Given this list of marker genes TLX3, PRIM1, NUP107, ASPA, SFXN1, MZB1, DPH1, MGAT4C, CCDC112, KCNAB1, LRP8, VPS8, ANKRD9, SELENOV, EHMT1, MAN1B1, SPATA2L, IFI30, SIRT3, FBF1, SERBP1, KCNK2, PPP1R36, SLC25A31, RAMP1 (receptor activity modifying protein 1), P2RY1, NPM1, FREM2, ERAS (NCBI Gene Id 3266), MPV17L2, DMAP1, KRTAP19-3, WT1, PPP1R1C, DAZ2, TMPRSS11E, MTSS2, KANSL1, IGKC, MYOZ3 (myozenin 3), SCHIP1, BMPR1B, PRAMEF25, POLD1, CTNNBL1, ATP1B4, NDP, TLR3, SH2D4A, TDRD1, FOXD4L1, HHEX, MS4A13, CENPQ, SERPINB8, PADI6, ANKZF1, VIL1, CLDN5, TNS3 (tensin 3), OR2S2, IQCE, DCAF4, SLC47A1 (solute carrier family 47 member 1), MEF2C, COLEC11, IGLC7, ERC2, DPP10, ARHGAP33, TEX12, THEM4, TBCE, TUBG1, ADRA1B, BLOC1S2, LACTBL1, CISD1, ZDHHC13, KMO, TM7SF2, RNGTT (RNA guanylyltransferase and 5'-phosphatase), S1PR1, PAPLN, SLPI, SPON2, PRKAG3, TUBA4A, SIGLEC10, CADM2, GDPD1, TBX3, CYP17A1, SLC25A51 (NCBI Gene Id 92014), C7orf50, CABLES1, SETD1B (SET domain containing 1B, histone lysine methyltransferase), TBC1D31, MGST3, GPX6, PRAM1, OTUB2, LGALS8 (NCBI Gene Id 3964), ZNF454 (zinc finger protein 454), TREH, HLA-DQA1, TMEM184C, CCDC124, SYT2, UST, CXXC5 (CXXC finger protein 5), DCP1B, ERLIN1, CD74, SLC7A13, ENSG00000285566, SPTAN1, CIMIP7, CHRM3, EIF6, ENPEP, CYP4F2, PXN, ATP5MK, PCSK1N, PHACTR4, NCBP2AS2, IPO5, THEMIS2, ZCCHC14, PACRG (parkin coregulated), SNRPD2, TTLL8, UPK3BL1, SLC7A6, PPIE, TMEM132C (transmembrane protein 132C), CCL13, SPAG17 (NCBI Gene Id 200162), EPPK1, DNAJC30, P3H2, PIGQ, COA8, LYPD5, HLA-DRB1, DDX19A, GAL3ST2, SNAP25, RAB4B, MXRA7, SEC31A, USP12, WIPI1, GDF5, AIFM3, BPIFA1, SPPL2B, MYH8, IGHMBP2, HAUS1, GON4L, CLCA1, ZZEF1, ENTPD3, GC, ZNRD2, ADGRB3, SALL3, SNX5, SCARB1, ZNF616, SUSD1, PKIA, GCM1, SGCE, SPARC, SHROOM1, CAVIN3, KRT31, THAP12, TCP1, BLTP2, KIF24 (kinesin family member 24), MPP7, RPS6KB1, TMEM126A, RSPH4A, MAPK10, WBP1L, OLFML1, VRK3, FOXD3, LBP, FHL2, SEMA3B, GPC1, SLC37A4, COMMD9, GLRX5, here is a description of the gene set: from publication Hale JS, Youngblood B, Latner DR, Mohammed AU, Ye L, Akondy RS, Wu T, Iyer SS, Ahmed R (PMID 23583644) Human Gene Set: GSE43863_TFH_VS_LY6C_INT_CXCR5POS_MEMORY_CD4_TCELL_DN Genes down-regulated in CD4 SMARTA memory T cells: follicular helper (Tfh) versus Ly6c int CXCR5+. species: Homo sapiens CD4 T follicular helper (Tfh) cells provide the required signals to B cells for germinal center reactions that are necessary for longlived antibody responses. However, it remains unclear whether there are CD4+ memory T cells committed to the Tfh lineage after antigen clearance. Using adoptive transfer of antigen-specific memory CD4+ subpopulations (based on CXCR5 and Ly6c expression)in the LCMV infection model, we found that there are distinct memory CD4+ T cell populations with commitment to the Tfh and Th1 lineages. Our conclusions are based on gene expression profiles, epigenetic studies and phenotypic and functional analysis. The gene expression profiles of virus-specific CD4 T cell subets at effector and memory stages is presented here.